The following is a description of a gene set: Mouse Gene Set: GOBP_CANALICULAR_BILE_ACID_TRANSPORT species: Mus musculus Enables the transfer of bile acid from one side of a hepatocyte plasma membrane into a bile canaliculus. Bile canaliculi are the thin tubes formed by hepatocyte membranes. Bile acids are any of a group of steroid carboxylic acids occurring in bile, where they are present as the sodium salts of their amides with glycine or taurine., and this is the list of marker genes: Abcc2, Aqp9, Abcb11, Abcc3, Mip, Aqp8